Given this list of marker genes CYP2E1, ALOX5, GGT1, GPR32, CYP2C8, ALOX15B, LTC4S, EPHX2, PTGIS, PTGES, DPEP1, PTGS2 (prostaglandin-endoperoxide synthase 2), ALOX12, GSTP1, PLA2G4A, CYP2D6, PTGDS, ALOX15, CYP1A2, FADS2, FADS1, ELOVL5, CMKLR1, PTGS1, TBXAS1, FPR2, LTA4H (NCBI Gene Id 4048), CYP3A4, GSTM4, CYP2C9, ELOVL2, HPGD (15-hydroxyprostaglandin dehydrogenase), here is a description of the gene set: species: Homo sapiens Omega-3-fatty acids in senescence Human Gene Set: WP_OMEGA3FATTY_ACIDS_IN_SENESCENCE